The following is a description of a gene set: Human Gene Set: HP_PONTOCEREBELLAR_ATROPHY Atrophy affecting the pons and the cerebellum. studied in species Homo sapiens Pontocerebellar atrophy, and this is the list of marker genes: DPM1, RORA, VPS4A, CCDC88C, LAMA2, SETX, CLTC, FA2H, INTS11 (integrator complex subunit 11)